The following is a description of a gene set: Human Gene Set: HP_FREQUENT_TEMPER_TANTRUMS Frequent temper tantrums species: Homo sapiens Temper tantrums that occur more frequently compared to the temper tantrums that are a part of the normal developmental process., and this is the list of marker genes: CSNK2A1, SETBP1, KAT5, SATB2, ARPC4, CLCN3, OFD1, TLK2, TAOK1, ACBD6